The following is a description of a gene set: Any process that modulates the frequency, rate or extent of the chemical reactions and pathways resulting in the formation of proteins by the translation of mRNA or circRNA. species: Mus musculus Mouse Gene Set: GOBP_REGULATION_OF_TRANSLATION, and this is the list of marker genes: Ireb2, Aire, Akt2 (NCBI Gene Id 76480), Cdk4, Ddx39b (DEAD box helicase 39b), Ngrn, Mpv17l2, Ifrd2, Ncl, Cnot9, Eif4g2, Rbms3 (NCBI Gene Id 71506), Rack1, Wt1, Gtdc1, Zar1l, Casc3, Impact, Tsc1, Aars1, Eif2ak3, Rps27l, Rpl5, Dapk3, Tent2, Nmnat2 (NCBI Gene Id 98444), Trub2, Cirbp, Syncrip, Lsm14b, Smyd5, Tyms, Mir186, Igf2bp3, Prkca, Ngdn, Caprin1, Cnot1, Eef2k, Klhl25, Paip2b, Aplp1, Magoh, Il6, Lin28a, Rida, Nsun3, Mirlet7b (microRNA let7b), Larp4b, Pum1, Mir125a, Sarnp, Mir3960, Mir9-1, Dnajc1, Rpl13a, Ang, Igf1, Rpl10-ps3, Xrn1, Akt1, Tpr, Boll, Gzmn, Wfs1, Sepsecs, Neurl1a, Eif4enif1, Mir1247, C1qbp, Ncbp2, Malsu1, Adad1, Eif3d, Fech, Tmed2, Usp16, Sox4, Rps6kb1 (NCBI Gene Id 72508), Eif4e, Hbb-bs, Rps4x (NCBI Gene Id 20102), Ogfod1, Ptcd3 (pentatricopeptide repeat domain 3), Eif6, Mir135a-1, Eif4ebp1, Mtg2, Zar1 (NCBI Gene Id 317755), Tia1, Nolc1, Fmr1, Ern1, Fxr1, Eif2ak2, Tsfm, Prkdc, Enc1, Shmt2, Ncbp1, Ago2, Tob1, Eif4ebp2, Mrps27, Mvk, Pld1, Pelo (pelota mRNA surveillance and ribosome rescue factor), Rps9, Bcl3, Rbm24, Rbm3, Barhl2, Map3k20, Eprs1, Msi2, Serp1, Nanos1, Ppp1r15b, Mcts1, Btg2, Fastkd2, Piwil2, Scrib, Slc35a4, Eif2s1 (NCBI Gene Id 76274), Tarbp2, Upf3b, Akap6, Plxnb2, Tnrc6c, Wtip, Pum3, Mknk1, Rps6kb2, Zcchc4, Mtor, Nck2, Ago1, Mettl3, Coa3, Fxr2, Gzmb, Otud6b, Poldip3, Gapdhrt, Trim71, Ybx1, Npm1 (nucleophosmin 1), Pura, Krt13, Eif4a3l2, Mtg1, Ythdf1, Eif2ak4, Foxo3, Samd4b, Cnot6, B3gntl1, Alkbh1, Cyfip1, Polr2g, Ep300, Abce1, Fastkd3, Khdrbs1, Eif2a, Pkp1, Trnau1ap, Zfp385a, Zfp598, Krt17, Piwil1, Dhx9, Tent5b (NCBI Gene Id 242690), App, Dap, Cdk5rap1, Shfl (NCBI Gene Id 319278), Mir1a-2, D1Pas1, Prg3, Cnot7, Bc1, Eif5a2, Mirlet7g, Eefsec, Pcif1, Mettl8, Lsm14a, Ddx3x, Zfp706, Cnot8, Niban1, Unk, Etf1, Abcf1, Dhx36, Upf1, Pym1, Trap1, Alkbh5, Elavl1, Aco1, Caprin2, Rcc1l, Nsun4, Tnrc6a, Ang5, Mapk1, Gcn1, Rps14, Bzw2, Paip1, Ddx25, Qki, Dazl, Rpl10, Pus7, Mettl18, Rps3, Gigyf2, Eif4a3l1, Cnot11, Eif1, Nat10, Rpl38, Dhx29, Mir448, Zfp36l1, Habp4, Grb7, Mettl5, Uhmk1, Rmnd1, Patl2, Dapl1, Sesn2, Ptbp1, Mir143, Lrpprc, Mettl14, Ptafr, Mir466l, Rplp1, Zcchc13, Eif4e2, Kbtbd8, Eef2, Ythdf2, Srp9, Taco1, Thbs1, Eif4a3, Rara, Igf2bp2, Ppp1r15a, Erbb2, Eif4e3, Gapdh (glyceraldehyde-3-phosphate dehydrogenase), Ago3, Pink1, Eif3k, Xbp1, Mknk2, Rpusd3, Dapk1, Ptk2b, Rgs2, Hbs1l, Sh3bgrl, Eif3e, Cnot3, Padi6, Upf3a, Rbm4b, Igfbp5 (insulin-like growth factor binding protein 5), Mif4gd, Cnot2, Nsun5 (NCBI Gene Id 215084), Eif4g3, Prkch, Secisbp2, Dus3l, Sars1, Eif2ak1, Patl1, Eif3b, Gapdh-ps15, Cnot6l, Pml, Rpl26, Zfp36, Ppp1ca, Cnbp (cellular nucleic acid binding protein), Prmt1, Nanos3, Rbm4, Msi1, Gspt1, Eif4g1, Limd1, Ythdf3, Rpusd4, Hnrnpd, Pstk, Eif5, Pabpc1, Serbp1, Bzw1, Cpeb2, Pa2g4, Hnrnpu, Eif5b, Paip2, Mapk3, Mir1a-1, Uqcc2, Mrpl13 (mitochondrial ribosomal protein L13), Bank1, Jmjd4, Guf1, Dnajc3, Parp16, Eif5a, Larp4, Calr, Samd4, Ucn, Tnrc6b, Cnot10, Eif4ebp3, Larp1, Ogt, Csde1, Pcbp1, Tnf (NCBI Gene Id 21926), Ssb, Cpeb1, Ilf3, Tcof1, Igf2bp1, Rnf139, Elavl4, Cpeb3, Mir7116, Mir875, Alkbh3, Trmt10c, Mapkapk5, Ago4, Itga2, Eif2b5, Piwil4, Inpp5e, Ybx2, Ddx6, Prr16, Rxra, Cyp1b1, Ajuba, Gzmc, Gapdhrt2, Pum2, Rbm8a, S100a9, Shmt1, Ctif, Pkm, Nck1, Cpeb4, Mir7b, Larp6, Gemin5 (NCBI Gene Id 216766), Nanos2 (NCBI Gene Id 378430)